Given this list of marker genes Adm, Ramp3, Calcrl, Adm2, Ramp2, here is a description of the gene set: The series of molecular signals initiated by an extracellular adrenomedullin combining with a dimeric adrenomedullin receptor on the surface of the target cell. studied in species Mus musculus Mouse Gene Set: GOBP_ADRENOMEDULLIN_RECEPTOR_SIGNALING_PATHWAY